The following is a description of a gene set: studied in species Homo sapiens Reactome Pathway: Biosynthesis of E-series 18(S)-resolvins Eicosapentaenoic acid (EPA), a major ω-3 polyunsaturated fatty acid (PUFA) found in fish oil is the source of E-series resolvins, one of the specialized proresolving mediators (SPMs) that show potent anti-inflammatory and pro-resolving actions. The initial transformation of EPA can be mediated by either cytochrome P450s and/or aspirin-acetylated cyclooxygenase-2, resulting in stereospecific formation of 18(R)- and 18(S) E-resolvins. Combinations of oxidation, reduction and hydrolysis reactions determine the type of E-resolvin formed (RvE1, RvE2 or RvE3) (Serhan & Petasis 2011). Aspirin acetylation of cyclooxygenase isoforms results in changed activities. Acetylation of cyclooxygenase-1 results in its inhibition and thereby halting production of inflammatory mediators. However, acetylation of cyclooxygenase-2 transforms its enzyme activity from a cyclooxygenase to a lipoxygenase, thereby blocking prostaglandin biosynthesis and, additionally, initiating the production of SPMs. The biosynthesis of 18(S) E-resolvins is described here. part of: Biosynthesis of EPA-derived SPMs, and this is the list of marker genes: LTA4H, GPX4, ALOX5, ALOX15, HPGD